Given this list of marker genes PTHLH, SKI, IFT52, RAB3GAP2, CRPPA (CDP-L-ribitol pyrophosphorylase A), CD247, CHST3, LMNB2, HINT1, FGD1, DHCR24, LARGE1, ADAMTS10, TNNT3, TNNI2, BMPR1B, ITPR1, NSUN2, TGDS, KIF22, TCF4, POMT2, PORCN, FLNB, FKTN, UBAP2L, MAP3K7, RBPJ, PEX2, PRKG2, XYLT1, ACVR1, SMOC1, GLI3, HOXD13, POMT1, ERI1, ZFX, COG4, SMARCA2, PTPN2, WNT7A, IQCE, GNAS, PDE4D, CANT1, POMGNT1, DYM (NCBI Gene Id 54808), DAG1, CTBP1, MAPK1, TRPV4, VPS13B, POC1A, EP300, IL2RA, HEPHL1, RSPRY1, B3GLCT, PTPN22, UBE3B, MAP3K20, PRMT7, ZBTB20, CPLX1, MEG3 (maternally expressed 3), IFIH1, ZNF407, CDC42BPB, FKRP, DDR2, GDF5, EBF3, WDR26, PIK3CD, VAC14, SRY, FIG4, LETM1, COL2A1, SALL1, RIPK4 (NCBI Gene Id 54101), TUBB3, VPS35L, FBN1, PIGS, KNSTRN, FAT4, IL2RB (interleukin 2 receptor subunit beta), B3GAT3, MYH8, HOXA13, LIG4, NPR2 (NCBI Gene Id 4882), HDAC4, FGFR2, RTL1, DCHS1, FBN2, IFT140, LZTFL1, AKT1, PIEZO2, FIBP, TRPS1, NAA10, IFT56, ABCC9, TBX5, PEX5, MMP2, TWIST1, PRG4, MAFB, RXYLT1 (NCBI Gene Id 10329), TP63, B4GAT1 (NCBI Gene Id 11041), POMGNT2, POMK, PRKAR1A, RAB33B, SIL1, LRP5, HSPG2, SH3PXD2B, RAB23, PEX1, NALCN, FGF9, IHH, CHSY1, POR, KCNJ2, MET, NSD2, FBLN1, B3GALNT2, ATL3, FGFR1, B3GALT6, PEX7, DHCR7 (NCBI Gene Id 6589), SLC35A2, SLC26A2, LMBR1, COL4A1, ERCC6, PTH1R, STAT4, PHYH (phytanoyl-CoA 2-hydroxylase), SOX9, SHOX, EZH2, FLNA, ANKRD55, DLK1, NEK1, FGFRL1 (NCBI Gene Id 54966), GUSB, here is a description of the gene set: studied in species Homo sapiens Abnormalities of the metatarsal bones (i.e. of five tubular bones located between the tarsal bones of the hind- and mid-foot and the phalanges of the toes). Abnormal metatarsal morphology Human Gene Set: HP_ABNORMAL_METATARSAL_MORPHOLOGY